The following is a description of a gene set: Mouse Gene Set: GOCC_HEMIDESMOSOME A cell-substrate junction (attachment structure) found in epithelial cells that links intermediate filaments to extracellular matrices via transmembrane complexes. In vertebrates, hemidesmosomes mediate contact between the basal side of epithelial cells and the basal lamina. In C. elegans, hemidesmosomes connect epithelial cells to distinct extracellular matrices on both the apical and basal cell surfaces. studied in species Mus musculus, and this is the list of marker genes: Lama3, Itgb1, Itgb4, Plec, Eppk1, Actr3, Dst, Itga6, Col17a1, Erbin